The following is a description of a gene set: Abulia is characterized by difficulty in initiating and sustaining spontaneous movements; the person often appears frozen but will move hesitantly on request. There are frequently substantial reductions in emotional responsiveness, spontaneous speech, and social interaction. The individual appears to be content to remain still and inactive with minimal movement, but moves or reacts hesitantly in response to interactions. Human Gene Set: HP_ABULIA species: Homo sapiens Abulia, and this is the list of marker genes: MAPT, TMEM106B (transmembrane protein 106B), CHMP2B, GRN, PSEN1, TREM2, VCP, SQSTM1, NOTCH3 (notch receptor 3), HTRA1